The following is a description of a gene set: Lysosphingolipid and LPA receptors studied in species Mus musculus Mouse Gene Set: REACTOME_LYSOSPHINGOLIPID_AND_LPA_RECEPTORS, and this is the list of marker genes: S1pr4, Lpar2, S1pr3, Lpar5, Plppr2, S1pr1, S1pr5, Lpar3, Lpar1, Plppr1, S1pr2, Plppr4, Plppr5, Plppr3